Given this list of marker genes Hey1, Ccn1, Mir19a, Smad7, Sox11, Rbpj, Nos3, Cfc1, Ift88, Nrp2, Dnah11, Rbm15, Smad4, Smo, Tgfb2, Fzd2, Mir92-1, Egln1, Mdm2, Tbx3, Cited2, Smad6, Nsd2, Zfpm2, Notch1, Parva, Bmpr1a, Tbx5, Heyl, Eng, Mir20a, Mir19b-1, Isl1, Nrp1, Chd7, Nkx2-5, Gata6, Vangl2, Sav1, Bmpr2, Nfatc1, Aplnr, Fgfr2, Hand1, Acvr1, Mir17, Id2, Bmp5, Msx2, Tgfbr1, Tbx20, Trp53, Notch2, Fgfrl1, Hes1, Slit2, Mks1, Wnt11, Robo1, Bmp7, Zfpm1, Adamts19, Bmp4, Hey2, Fgf8, Sox4, Pitx2, Slit3, Tbx2, Fzd1, Jag1, Dvl3, Dhrs3, Sema3c, Gata4, Mir18, Lrp2, Tgfbr2, Lrp6 (NCBI Gene Id 77387), Robo2, Tgfbr3, Nog, Tbx1, Gja5, Prox1, here is a description of the gene set: The process in which the anatomical structure of a cardiac septum is generated and organized. A cardiac septum is a partition that separates parts of the heart. Mouse Gene Set: GOBP_CARDIAC_SEPTUM_MORPHOGENESIS species: Mus musculus